Given this list of marker genes PTK2B, ITGB3, C1QL2, LRFN1, NRXN1, ABI3, LRRC4B, CSMD2, SHANK3, CRIPT, LRRC4, LATS1, NLGN2, SLITRK3, IL1RAP, CNTNAP1, NTRK3, SLC30A1, SHANK1, FGFR1 (NCBI Gene Id 84151), PTPRS, C1QL3, LRFN4, ZDHHC12, DLG1, NPTX1, CASKIN1, SYNGAP1, PRICKLE1, GIT1, ARF6 (NCBI Gene Id 63379), CBLN1, CDH2, PPFIA2, NLGN1, LRRTM2, PTEN, RELN, ZMYND8, TMEM108, OPHN1, RAPSN (NCBI Gene Id 85713), NRXN2, LILRB2, GRID2 (glutamate ionotropic receptor delta type subunit 2), CFL1, PTPRD, here is a description of the gene set: studied in species Homo sapiens Human Gene Set: GOBP_POSTSYNAPTIC_DENSITY_ORGANIZATION A process that results in the assembly, arrangement of constituent parts, or disassembly of a postsynaptic density, a region that lies adjacent to the cytoplasmic face of the postsynaptic membrane at excitatory synapse.